Given this list of marker genes ARL10, FOXP2, FXR1 (NCBI Gene Id 8087), ADRA2A, FGF10, MGAT4C (MGAT4 family member C), TMEM243, HSPB2, LY96, CHRNB2, C5orf15, CUTC, PHYHIPL, BCL9, KLF3, TBX19, UBOX5, BAIAP2, CHAF1B, SAV1, NUCB1, TESK1, RBM17 (NCBI Gene Id 84991), TSPYL1, RAP2C, HDAC1, RHOH (NCBI Gene Id 399), STARD3NL, ODC1, SART3, PCCA, C1QTNF4, DNAH8, PCYT1A, CA13, C8orf33, DBH, DPCD, EEF2K, S1PR4, SGK3, IFT172, TREM2, USB1, FANCA, TPM2, ATP6V1C2 (NCBI Gene Id 245973), RNF34, RNF19B, TNC, NOC4L, FKBP10, MARCKS, NCOA5, SLU7, SELE, PDCD10, BFAR, PIK3AP1, FEV, RCN1, NFKBIZ, CCDC92, APOE, DUSP14, SERPINC1, PDSS1, SFXN2, MPO, RNPEP, RELL1, GFRA2, LGR6, CLIP1, NUB1, RD3, KCNMB2 (potassium calcium-activated channel subfamily M regulatory beta subunit 2), APOBEC3B, ALDH1L1, PLAT, ABCG2, CAB39L (NCBI Gene Id 81617), ETV6, RPP25L, TLK2, FGF23, PLPPR2, ANKS1A, COX15, ATAD1, FBXO38, TMEM209, TCTN2, KALRN, RTP3, GPR37L1, NCOA1, CHST15, SH3BP2, IL15RA (interleukin 15 receptor subunit alpha), DBNL, CXCL9, CD300LF, SFTPB, SLC25A28, KPNA3, CPNE3, PECR, LTA, RNF114, NOL7 (NCBI Gene Id 51406), STAT3, SASS6, KCNAB3, MAML2, GTF2H4, GRM8, TANK, KBTBD4, HPCA, ASF1A, FGF5, IFITM2, SLC6A4, TRAPPC14, VPREB3, TLE4, TWSG1, SORL1, CRISPLD1, EIF6, MYD88, SLAMF8, KRTAP4-3, IFT22, H2AC25 (H2A clustered histone 25), ZNF22, HINFP, SCNN1G, TTC16, SLC40A1, DENND1A, UNC93B1, TRIOBP, CEPT1, STAT5B, PAXBP1, ITGA4, PPM1D, PARP4, SUV39H1, CLCN1, DPF3, TLR6 (toll like receptor 6), IRF2, TRA2A, MCM10, TMEM163, FRAT1, POLR3C, PHIP, RAB9A, TOX4, TFIP11, USP47, IL12A, CLCF1, EEIG1, KCTD12, LCK, SLC30A1, MAP4K2, GNB3, COA5, KCTD10, FBXO25, BLTP1, VCAN, RIMKLB, ENOX2, PEX13, CNP, ZFAND5, MUC13, FOXRED1 (FAD dependent oxidoreductase domain containing 1), IDO1, PRDX4, NDRG1, CD164, PLEKHF2, SGK1, RGL1, GATAD2A, NUDT9, GNG11, NRROS, PCSK7, ANKIB1 (ankyrin repeat and IBR domain containing 1), STIP1 (stress induced phosphoprotein 1), PLEKHA2, here is a description of the gene set: species: Homo sapiens Human Gene Set: GSE17721_PAM3CSK4_VS_CPG_6H_BMDC_DN Genes down-regulated in comparison of dendritic cells (DC) stimulated with Pam3Csk4 (TLR1/2 agonist) at 6 h versus DC cells stimulated with CpG DNA (TLR9 agonist) at 6 h. mouse primary BMDCs were stimulated with tlr ligands and gene expression changes were profiled on Affymetrix arrays from publication Amit I, Garber M, Chevrier N, Leite AP, Donner Y, Eisenhaure T, Guttman M, Grenier JK, Li W, Zuk O, Schubert LA, Birditt B, Shay T, Goren A, Zhang X, Smith Z, Deering R, McDonald RC, Cabili M, Bernstein BE, Rinn JL, Meissner A, Root DE, Hacohen N, Regev A (PMID 19729616)